Given this list of marker genes ITGB7, VANGL2, SECTM1, HIVEP1, RELB, CD200, PATL2, ADGRE5, YAF2 (YY1 associated factor 2), STARD5, BCL3, ICAM1, ZHX2, GPR15 (NCBI Gene Id 2838), ABHD4, IL1RL1, RAPGEF5, QKI, PHC3 (NCBI Gene Id 80012), RTL5, RDH12 (NCBI Gene Id 3789), B3GNT2, SULF2 (sulfatase 2), CFAP410, SDHAF1, DAPK1, SKI, WIPI2, SMC4, TAP2, GALM, DUBR, SH3BGRL, SPTAN1, CDC42SE2, SELENOP, HLA-G, PGGHG, ZNF280B, TNFRSF25, STAT5A, SCIN, PEX16, USP6NL, STK38, IFNGR1, UBASH3A, CRIM1, GPX4, VSIG10, CD72, WDR35, BRPF3, PHTF2, SMAD4, IQCB1 (IQ motif containing B1), CHCHD10, MAN1A1, FBXL3, SYT11, SNX9, MAPKAPK2, TAPBP, PEAK1, RIPK2, SWAP70, POC1B, CASP3, LIG4 (NCBI Gene Id 3981), DNPEP, CALCOCO1 (NCBI Gene Id 57658), NMNAT1, PXMP2, REEP3, AFF1, BACH2, EXOSC8, RALGPS2, GBP6, IFT70B, IRF2, CAVIN1, LPCAT1, TIAM1, PIP5K1B, PEX11A, CASP4, TEX15, RRAD, PTMS, RLIG1, LAD1, CELF5, CYTH3, KIAA1958, METTL8 (methyltransferase 8, tRNA N3-cytidine), LTB, TULP3, BICD2, BCL6, HOPX, DGAT2, CSTPP1, AVEN (NCBI Gene Id 57099), SLC22A5, GTDC1, RERE, GFI1, N4BP2, PPM1B, SLC23A2, BIRC3, RHOF, FBXO25, GNA12, ABCG1, BICDL1, MCU, EPB41L2, TBXA2R, STX2, IP6K1, DUSP16, IL6R, STON1, LRRC8D, WBP2, NUCB2, NT5DC3 (5'-nucleotidase domain containing 3), FCMR, GATA1, ERBB3, SLC35D2, AP1M2, IRF9, JDP2, ZCCHC18, TENT5C, SMAD7, BTD, YPEL3, ICA1, YPEL2, ZNF608, SUSD6, TTC8 (tetratricopeptide repeat domain 8), SNX16, EMC2, POGLUT2, BMAL1, CPLANE1, CNST, MARVELD1, RNF19B, BIRC2, ALDH6A1, GRIK5, HLA-E, PLAGL2, GIMAP6, FMO5, RALGDS, KIZ, PLOD2, DONSON, IL2RB, LIX1L (NCBI Gene Id 128077), ARL13B (NCBI Gene Id 200894), CLIC4, RBM38, NFKBIB, TBC1D17, NDRG1, JPT1, SMC6, MAF1, MTMR3, ARMCX1, KIF7, ADD1, RAB33B, ARHGAP20, AMFR, HIF1A, SCARB2, REL, SPTB, ZFAND6, PTPRS, TMEM123, GPRASP1, EDEM1, C9orf152, EML2, IER5L, H2BC3, LAMC1, TP53INP1, TLE2, PARP14, here is a description of the gene set: Genes up-regulated in CD4 T conv: over-expressing IKZF4 and LEF1 versus control. from publication Fu W, Ergun A, Lu T, Hill JA, Haxhinasto S, Fassett MS, Gazit R, Adoro S, Glimcher L, Chan S, Kastner P, Rossi D, Collins JJ, Mathis D, Benoist C (PMID 22961053) Human Gene Set: GSE40277_EOS_AND_LEF1_TRANSDUCED_VS_CTRL_CD4_TCELL_UP The transcription factor FoxP3 partakes dominantly in the specification and function of FoxP3+ CD4+ T regulatory cells (Tregs), but is neither strictly necessary nor sufficient to determine the characteristic Treg transcriptional signature. Computational network inference and experimental testing assessed the contribution of several other transcription factors (TFs). Enforced expression of Helios or Xbp1 elicited specific signatures, but Eos, Irf4, Satb1, Lef1 and Gata1 elicited exactly the same outcome, synergizing with FoxP3 to activate most of the Treg signature, including key TFs, and enhancing FoxP3 occupancy at its genomic targets. Conversely, the Treg signature was robust to inactivation of any single cofactor. A redundant genetic switch thus locks-in the Treg phenotype, a model which accounts for several aspects of Treg physiology, differentiation and stability. species: Homo sapiens